The following is a description of a gene set: from publication Whitfield ML, Sherlock G, Saldanha AJ, Murray JI, Ball CA, Alexander KE, Matese JC, Perou CM, Hurt MM, Brown PO, Botstein D (PMID 12058064) Human Gene Set: WHITFIELD_CELL_CYCLE_M_G1 Genes periodically expressed in synchronized HeLa cells (cervical carcinoma), with peak during the M/G1 phase of cell cycle. studied in species Homo sapiens The genome-wide program of gene expression during the cell division cycle in a human cancer cell line (HeLa) was characterized using cDNA microarrays. Transcripts of >genes showed periodic variation during the cell cycle. Hierarchical clustering of the expression patterns revealed coexpressed groups of previously well-characterized genes involved in essential cell cycle processes such as DNA replication, chromosome segregation, and cell adhesion along with genes of uncharacterized function. Most of the genes whose expression had previously been reported to correlate with the proliferative state of tumors were found herein also to be periodically expressed during the HeLa cell cycle. However, some of the genes periodically expressed in the HeLa cell cycle do not have a consistent correlation with tumor proliferation. Cell cycle-regulated transcripts of genes involved in fundamental processes such as DNA replication and chromosome segregation seem to be more highly expressed in proliferative tumors simply because they contain more cycling cells. The data in this report provide a comprehensive catalog of cell cycle regulated genes that can serve as a starting point for functional discovery. The full dataset is available at http://genome-www.stanford.edu/Human-CellCycle/HeLa/., and this is the list of marker genes: MRPS18B, ILF2, USP6NL, NUDT4, AGPAT3, DCTN6, NUDCD2, MTPN, UBE2D3, CCSAP, ZCCHC10, TCERG1, TMEM138, NUFIP2, TAF9, SLC39A10, GDF15, MLLT6, AOC3, NFIA, RPL13A, ZPBP, GRPEL1, MRPL19, HSPA8, SRSF3, AFAP1, TICAM2, JMJD1C, YY1, HMG20B, ANP32E, TOB2, DCP1A, ZNF24, IFIT1, KPNB1, CEP70, KDM5B, FXR1, CDK7, VANGL1, SNHG16, LRIF1, HIF1A, AGFG1, TROAP, TSC22D1, LARP7, AOC2, SNUPN, DKC1, ZFAS1, ELP3, CYTH3, AKAP13, TULP4, NOS1, LYAR, PCF11, CDC42, PPP6R3, CBX3 (NCBI Gene Id 82756), LNP1, TLE3, MRPS2, PLIN3, PSEN1, ZNFX1, GSPT1, AMD1, PTMS, MSL1, VCL, WIPF2, NFIC, RAD21, RHEB, KIAA0586, SINHCAF, MORF4L2, NUP37, VPS37C, PTTG1, ODF2, C3orf62, C4A, CDKN3, FRS2, WWC1, CTR9, NUCKS1, ZSCAN5A, CWC15, PPP2CA, TOP1, LARP1, ANTXR1, DSP, CRYBA1, KRAS, CCND1, LINC00641, CNIH4, BTBD3, DYNLL1, ENTREP3, DNAJB6, PRC1, RAB3A, XPO4, NCS1, CD24 (CD24 molecule), OPN3, PPP2R2A, PAK1IP1, CEP20, DEXI, IFIT2, NCOA3, PLK2, PBK, H2BC21, GSE1, FOXK2, GATA2